Given this list of marker genes CRTC1, STON2, CHP1, LDLRAP1, PBX1, DMD, ALCAM, ZNF516, TTC33, CTNNA2, RPRD2, BCL11B, MED9, CSMD2, ZNF445, LARP1, ANKRD20A3P, ASPH, OPA3, P2RY8, CEMIP, CLSTN1, DCAF10, N4BP3, CT55, PSG4, MAN2B2, TLNRD1, SERP2, PPTC7, FMR1, KAT6B, TBC1D7, PSG7, SMIM21, PSG1, CACNA2D1, TDRKH, STX3, PBX2, GGA3, MLXIP, STON1, AKTIP, GCNA, KIF1B, HSBP1, ZNF608, MRPL15, ANKMY2, RHOV, RBSN, HSDL1, HOXD4, GPR132, MLEC, RGP1, TECPR2, PGS1, BCL11A, SYNPO, CAPRIN1, EPHA7, TRIM66, ACVR2B, ISYNA1, MAN2A2, PSG8, TRABD2B, SDK2, GRAMD1B, ITFG2, DUSP7, RNF125, SCN4B, FGD6, TCEANC2, CAPZA1, UBE3A, PLEKHG7, SLC25A30, GAB2, VPS53, PDGFB, CASK, NIBAN1, C1RL, EPHB2, SUPT3H, AADAT, AHDC1, MAP3K13, MFSD6, CBX6, NOTCH2NLA, TC2N, GALK2, P2RY2, RP9, LCLAT1, GLCCI1 (glucocorticoid induced 1), CEP85, FZD3, FRMD3, CSMD3, NUDT16, RFX3, CHRM1, PRR15L (NCBI Gene Id 79170), NUP214, CLCN2, CRIM1, MEX3A, here is a description of the gene set: Genes predicted to be targets of miRBase v22 microRNA hsa-miR-6727-3p in miRDB v6.0 with MirTarget v4 prediction scores > 80 (high confidence targets). species: Homo sapiens Human Gene Set: MIR6727_3P from publication Chen Y, Wang X (PMID 31504780)